Given this list of marker genes OPRM1, GCNT2, MTMR6, CREB5 (NCBI Gene Id 9586), GET4 (NCBI Gene Id 51608), ELAVL2 (ELAV like RNA binding protein 2), LPP, PTPRT, ZNF792, ST7, TOX3, PEX19, ADORA2A, HGF, CCDC144A, HCAR3 (hydroxycarboxylic acid receptor 3), FBN2, WWC3, LRIT3, ATP8B1, DPP4, SAE1, MLXIP, SPCS3, HAPSTR1, ZC3H7A, COX5A, SKI, ANGPT1, DLG5, PERP, TRMT11, UBA6, ANGPTL1, AQP11, ZCCHC24, RAB22A, HAS2, IGF2R, ZNF282, NKAPD1, HLTF, PTP4A1, RPS6KA5, CPNE8, KMT5A, FZD4, MEIS2, ELAVL3 (ELAV like RNA binding protein 3), EFNB3, TCF12, YPEL4, NBR1, CLIP4, SGIP1, FRAS1, M6PR, ENTHD1, DHH, MAPK9, SSRP1 (NCBI Gene Id 6749), ZFHX3, UBA2, VWA8, RAB14, SLC25A35, AP1S3, ZBTB20, GLIS3 (NCBI Gene Id 648268), ZNF629, CCNY, ISM1, NAA40, ZBTB7C, ENDOU, PPIC, RPS6KC1, EEF1E1, SEPTIN11, FUT9, ADCY1, CELF2, NCOA7, DNM2, DNAAF9, ARHGAP26, RHOBTB3, RSPO4, HCAR2, PTPRR, TP53INP1, BCL9, INO80D, JPH3, RGL1, MLLT3, TNRC6B, PPARGC1A, DYNC2H1, BIRC6, GDNF, COX10, ZDHHC14 (NCBI Gene Id 79683), PTPRD, CHCT1, VN1R1, SZRD1, CCNT2, EPHA5, C17orf58, THPO, MAP1LC3B, SOX11, C2CD2, ANO6, NTRK2, RIOK1, CCND2, ZCCHC10, SPRY3, NOVA1, AP3M1, GAN, BICC1, ABRAXAS2, TTYH1, IGFBP5, RASL10A, CHP1, ARL8B, SPRYD7, CD200, AP2A2, COG5, ARCN1, SPOP, PCGF3, SOX4, INTS2 (integrator complex subunit 2), PALM2AKAP2, MGAT3, CDK14, EXOC6B, TSC1, JARID2, RABGAP1L, SF3B1, ONECUT2, THSD4, RPS6KA3, PRAMEF12, ACSM5, ANKRD13A, TOMM70, KXD1, STXBP5, FNIP1, ACADL, PDCD6, MMP16, TAOK1, ITPR1, LSM5, HAPLN1, SHF (Src homology 2 domain containing F), SLITRK4, SIRT1, PLXDC2, ASPH, HYCC1, AFAP1, PHF13, HYAL4, SASS6, AMOT (angiomotin), SLC12A6, NBEA, MAPRE2, SAMD5, SOX14, BIRC2, MCCD1, VGLL3, ASXL3 (ASXL transcriptional regulator 3), C9orf72, YAE1, CDH4, TFEC, NFATC3, BMPR1A, EBF2, VAPB (NCBI Gene Id 9217), SEC61A2, SEC24D, ZNF521, DUSP14, PDE1C, TMEM156, WDFY2, BTBD1, GMEB1, SLC24A2, KLHL29, XRN1, SH3PXD2A, RUNX2, B3GNT5, TPPP, TRIM44, FRY, ZFP91, AEBP2, DPF1, RHOT1, CDK13, IST1, RELL1, ACAT1, ADCY6, STON2, MON2, ACSL4, CHN2, CNOT1, EVA1C, IKZF2, PRRX1, KHDRBS3, MCOLN1, NAPG, RTKN2, TMEM263, HNRNPUL1, NOP10, NR3C1, UEVLD, EZR, PRDM1, SMIM13, HOOK3, TMEM181 (NCBI Gene Id 57583), PRKRA, NAA15, LIG3, TMEM87A, EPHB2, TGFBRAP1 (NCBI Gene Id 9392), PPM1K, RIMS2, KLF12, UBP1, TMEM213, PIP4K2B, ACBD7, RASA3, FHIP1B, YPEL2, ANKRD13C, GPC3, FRS2, FAM168B, RAB40B, EIF2AK3, NRBF2, SH3TC2 (NCBI Gene Id 79628), EVC2, STOX2, PHOX2B, C2orf76, SLC25A24, NALF2, SLC43A1, ARHGEF33, BRWD1, C2orf68, ALCAM, RAB10, KHDRBS1, ADRA1A, SLC37A3, KCNA3, PRTG, FOXC1, SLC16A6, MTMR7, EPHB6, MAGI1, EPHA7, TMOD3, MYH15, FBXW7, CRKL (NCBI Gene Id 1399), TGFBR2, NR3C2, CAMK1, SCN2A, GNRHR, RNF170, RPL7L1, PIK3CB, ACER3, ZFHX4, ZNF605, HMCN2, IL7R, BEND6, CELSR3, ESCO2, TARDBP, LRP2, PHEX, SPRED1, CHD5, WDR76, TFAP2A, LATS1, ZNF699, FARP1, SNAP47, GSTM3, HNRNPA2B1, PID1, CCDC120, PLXNA2, AFF1, DRAP1, SOS1, LARP4B, ZNF423, WDR41, PCYT1B, P2RX1, GPBP1L1, HOXC8 (NCBI Gene Id 3224), DCUN1D3, RUBCN, FAM3B, SCML2, TMEM108 (NCBI Gene Id 66000), PTPRJ, IPO8, RERE, ESRRG, ARX, ATF2, UGDH, TMEM178B, AK4, FGD5, FAN1, ZKSCAN2, AP1S2, PKHD1L1, RREB1, ESYT2, TFAP2B, FOSB, TMEM87B, PRAMEF18, PRDM2, TMEM64, APH1B, RXFP1, DMTF1, AKAP1, SEMG2, INPP4A, TMEM237 (NCBI Gene Id 65062), CAPRIN1 (cell cycle associated protein 1), PDHX, DYRK1A, TENT5A, DNAJC13, JAK2, NEBL, HGSNAT, GPATCH2L (G-patch domain containing 2 like), FTSJ3, here is a description of the gene set: from publication Chen Y, Wang X (PMID 31504780) Genes predicted to be targets of miRBase v22 microRNA hsa-miR-204-5p in miRDB v6.0 with MirTarget v4 prediction scores > 80 (high confidence targets). Human Gene Set: MIR204_5P species: Homo sapiens